Given this list of marker genes Rp9, Plod1, Sec63, Alg5, Rho, Sec61a1, Gnrh1, Plod2, Sec61b, Zc3h12a, Uba1, Ssr4, Rps26, Maco1, Rps29, Aldob, Rps28, Srpra, Rpl27, Ccdc47, Srprb, Tmem97, Epm2a, Suco, Sec61a2, Sec61g, Pi4kb, Arl6ip1, here is a description of the gene set: The lipid bilayer surrounding the rough endoplasmic reticulum. Mouse Gene Set: GOCC_ROUGH_ENDOPLASMIC_RETICULUM_MEMBRANE species: Mus musculus